Given this list of marker genes ODAD4, WDR35, ODAD3, HSBP1, CFAP43, FBXW11, KIF1B, DNAH9 (NCBI Gene Id 8709), SUN2, CLIP3, AGBL4, HSPB1, RAB6A (RAB6A, member RAS oncogene family), LRPPRC, CFAP221, IFT57, BICDL1, SPAG17, MGARP, KIF27, TRAK2, GMNC, DAW1, OFD1, KIFC2, TMEM108, IFT22, RPGR, CDC42, DYNC2H1, CABYR, CILK1, TUBA1A, BBS12, WASF1, BLOC1S6, KIF5A, IFT140, PEX14, DYNC1H1, CCDC39, BLOC1S5 (NCBI Gene Id 63915), SOD1, BICDL2, CFAP54, BORCS6, DRC1, NETO1, TTC21B, CFAP53, RSPH4A, DLG2, IFT88, MAP1A, DNAAF1, IFT43, BICD2, STAU1 (NCBI Gene Id 6780), SPG11, CDR2L, KIFBP, UCHL1, MAP2, AP3M2, IFT52 (intraflagellar transport 52), CWH43, MAP1B, PCM1, RABGEF1, IFT80, FLOT2, IFT27, NDEL1, INTU, DNAH11, LCA5L, BLOC1S2, KIFAP3, KIF3B, OPA1, DYNC2I2, SPA17, UXT, RFX3, STAU2, KIF5C (kinesin family member 5C), IFT46, APP, ARL8B, DYNC1I1, ARMCX3, BICD1, UBB, SPEF2, MAP1S, TRAF3IP1, AP3S1, SYNE2, AGTPBP1, NHERF1 (NHERF family PDZ scaffold protein 1), ARL3, NEK10, FUZ, KIF5B, RHOT2, HTT, DCTN1, NDE1, RABL2B, TRIM46, DNAAF4, SPAG6, KLC3, SPAST, AP3B1, TUB, TRAK1, IFT122, MAPT, MAPK8IP3, NME7, DNAH5, DNAAF3, IFT172, DYNLT2B, AP3M1, CAMSAP3, NME5, DYNC2I1, NEFL, DTNBP1, TERF2, DYNC1I2, KIF21A, ARHGAP21, STK36, CLUAP1, ARL8A, RAB1A, DNAAF11, GAS8, RAB17, WDPCP, DNAAF2, SSX2IP, DYNLL1, SPG7, LCA5, ATG5, PURA, TTC21A, BAG3, RASGRP1, BORCS8, VANGL1, KATNIP, IFT20, KIF4A, STARD7, KIF17, COPG2, CEP131, BLOC1S4, FYCO1, SFPQ (splicing factor proline and glutamine rich), SUN1, KIF28P, IFT81, AP3B2, COPG1, TTLL1, AP3S2, SSNA1, APBA1, NPHP3, TRIM58, SYBU, DNAH1, AQP4, CFAP45, GJA1, BORCS5, KIF1A, RUFY3, WDR19, MAP2K1 (NCBI Gene Id 5604), IFT25, CCDC88C, MAK, ADCY10, PAFAH1B1, HDAC6, BLOC1S1, CCDC40, BORCS7, NEFH, TMEM230, IFT56, KIF13A, DYNC2LI1, FEZ1, BLOC1S3, CCDC38, RAB21, IFT70A, KXD1, TMEM201, HNRNPU, RUFY4, DNAI1, CCDC103, KIF1C, DST, RHOT1, KIF3A (NCBI Gene Id 11127), IFT70B, SPAG16 (sperm associated antigen 16), JHY, KIF16B, RAB27B, DPCD, LAMP1, ROPN1L, CLN3, IFT74 (NCBI Gene Id 80173), ACTR10, SNAPIN, HIF1A, ATG16L1 (NCBI Gene Id 81560), MREG, HAP1, AP3D1, STK11, here is a description of the gene set: Human Gene Set: GOBP_MICROTUBULE_BASED_TRANSPORT A microtubule-based process that results in the transport of organelles, other microtubules, or other cellular components. Examples include motor-driven movement along microtubules and movement driven by polymerization or depolymerization of microtubules. studied in species Homo sapiens